Given this list of marker genes SMC3, ESCO2, ESCO1, CDCA5, HDAC8, here is a description of the gene set: Human Gene Set: KEGG_MEDICUS_REFERENCE_COHESIN_ACETYLATION species: Homo sapiens Cohesin acetylation. Pathway ID: N01483. Pathway type: Reference. Pathway class: nt06512 Chromosome cohesion and segregation. Pathway Definition from KEGG: HDAC8 -| ESCO1,ESCO2 -- SMC3 -> CDCA5